Given this list of marker genes SLIT2, ID2, RYK, OPRM1 (opioid receptor mu 1, NCBI Gene Id 4988), RARB, NEURL1, DRD2, MIR222, SHANK3, NRXN1, FXR1, WASF3, TNFRSF1B, MYB, HOXB3, CTNNB1, HES6, LRTM2, TIAM2, SEMA3F, BDNF (brain derived neurotrophic factor), PTPRS, ELL3, POU4F2, NCMAP, OLIG2, FBXW8, DRAXIN, FGF13, NFATC4, PRUNE1, DAG1, S100B, NPTN, PCM1, GATA2, EGR2, RELN (reelin), CX3CR1, SOX11, KIT, LEF1, DHX36, SLIT1, TNFRSF21, LRRTM3, SRF, DKK1, B2M, IL34, FZD4, FEZF1, AGRN, PER2, QKI, KIFAP3, GPR37L1, REST, CTDSP1, LRRTM1 (leucine rich repeat transmembrane neuronal 1), SKI, RUFY3 (RUN and FYVE domain containing 3), AKT1, PARD3, FN1, MECP2, S100A10, NLGN2, DCT, FXR2, LRRTM2 (NCBI Gene Id 26045), L1CAM, SMURF1, KDM1A, LYN, HMGB2, TG, MAP6, TPPP, TP53, CHODL, ARHGAP4, TTBK1 (tau tubulin kinase 1), IL6ST, IST1, GHRL, GBX1 (gastrulation brain homeobox 1), CBLN2, EZH2, CDK18, MIR137, PARP6, AMIGO1, SEMA4A, PLXNB2, SEMA6C, PROX1 (NCBI Gene Id 5629), VAX1, ITPKA, VEGFA, EPHB1 (NCBI Gene Id 2047), NLGN3, SLC7A5, SERPINF1, ZNF335, RARG, IQSEC2, CUX1, DAAM2, NLGN1, FEZF2, SLITRK2, AMIGO3, NR1D1, GSX2, ST8SIA2, ANAPC2, BCL11A, HES5 (hes family bHLH transcription factor 5), APPL2, RNF112, EPHA7, CXCL12, CTNNA1, VSTM5, HES3, ADGRB2, E2F1, TYMP, RND2, BMAL1, DLL1, CLCN2, PRTG, IGF1, GRM5, METRN, NUMB, FGF2 (fibroblast growth factor 2), ANKRD27, MEGF8, DICER1 (NCBI Gene Id 4333), MIR221, LIF, SOX10, ADGRB3, ASIC2, SS18L1, CRABP2, DNAJB11, PTN, ATXN1, HMGA2, ADGRB1, SLITRK6 (NCBI Gene Id 84189), WNT7A (Wnt family member 7A), CHD7, MIR181C, CAPRIN2, NTRK2, DLG5, GPRASP3, FMR1, RNF6, NRP1, BAIAP2, MIR142, ROBO2, TENM4, PLXND1, NOS1, RB1, CLCF1, TRAK2, NOTCH1 (NCBI Gene Id 54781), PRMT5, PRKCA, EFNA5, SRPX2, NRDC, SRRT, OXT, IL6, DMRTA2, PLXNC1, ANXA2, KIAA0319, SORL1, VEGFC, EPHB2, SYNGAP1, DSCAM, GPER1, NKX6-1, DCC, FSTL4, LIMK1, HOOK3, CST7, ULK1 (NCBI Gene Id 8408), ASPM, PRKCH, YAP1, LRRN1, CX3CL1, SEMA4F, FLRT2, YWHAH, EEF2K, LRRC4B, HEYL, MIR181B1, SEMA3G, GOLGA4, PAFAH1B1, TIAM1, ITGB1, SLC30A1, NEFL, SEMA6D, DAB1, MAP3K13, LHX2, SOX8, GORASP1, ITGAX, MT3, RHEB, TWF2, RNF10, WNT2, DLX2, DLL4, EFNB3, LRP2, DOCK7 (dedicator of cytokinesis 7), BMP2, NOG, FIG4, ISLR2, NIN, DRD3, HDAC1, MYRF, HDAC2, CAPRIN1, SMARCD3, RTN4, KRAS, LPAR3, CDON, DISC1, SPP1, MIR125B1, STK11, MAP2K1, OBSL1, AMIGO2, RARA, UFL1, TPBG, DLX1, ROBO1, NTN1, DLL3, ZNF365, FLRT1, EIF2AK3, DIP2B, MAP1B, CAMK2B, NR2E1, TRIM32, FZD3, GBX2, STAU2, SIRT2, GRID2, THBS2, MAN2A1, MTOR, ZFYVE27, TGM2, PAX6, ZNF488, ADCY10, LIN28A, TMEM98, LINGO2, F2, SEMA5A, IDH2, MAPT, RASSF10, TSPO, LRRN3, PLAG1, DPYSL5, LRP4, SPEN, SPINT1, PAK1, CLSTN1, SLITRK1, LDLR, LTA, PLXNA3, ADNP, ID4, PTEN, PSEN1, RTN4R, PTPRD, KHDC3L (NCBI Gene Id 154288), NKX6-2, PRKCI, PPP1CC, SLITRK5, MACF1, BTG2, BHLHE41, IL1B, SEMA7A, CDKL3, IL1RAP (NCBI Gene Id 3556), HAP1, YTHDF2, CDK5, HEY1, KCTD11, MTMR2, ETV5, LRRC24, VSX2, HEY2, TP73, TLX2, MCF2, BRAF, SERPINE2, IFRD1, DUSP10, EPHA4, TLR2, CDH4 (NCBI Gene Id 79941), FERD3L, PTPN13, BMPR2, ELAPOR2, CXCR4, NGF, CUL7, TREM2, IL1RAPL1, PTPRZ1, ZEB2, SEMA4D, TNFRSF12A, LPIN1, TNF, CLSTN3, SLITRK4, NTRK3, HIF1A, WNT3, DYNLT1, WNT3A, SNW1, ASCL1, KIF14, BRINP1, XRCC5, ULK2, SMO, CDH1, PLXNB1, SHH, POU4F1, WDR62, NUMBL, HES2, HELT, GLI3, WNT5A, TRPC5, MAP2K2, NKX2-2, LRP8, RELA, JAM2, FLRT3, PITX3, MDK, CUX2, HES7, ATOH1, ZPR1, DBN1, TRAK1, TGFB1, SYNDIG1, NAP1L1, TRIM46, BMPR1A, HLTF, RGMA, GDI1, SHTN1, ASCL2, ARMCX5-GPRASP2, BMP7, MME, HDAC6, STK25, TRPV2, RAPGEF2, PPP3CA, NF2, NF1, TNR, TRIM11, SLITRK3, SPART, CTSC, SHOX2, FOXG1, MAG, MIR146A, MYCN, SKIL, CERS2, BHLHE40, LINGO4, LIG4, TRPC6, OTP, ABCC8, MAP2, CBLN1, NTRK1, NSUN5, TBC1D24, EPHB3, XRCC2, IFNG, LGI4 (leucine rich repeat LGI family member 4), HES1, RAB21, SYT4, CCL11, THY1, GFAP, PLXNB3, DLG1, BIN1, RGS14, CDKL5, CLSTN2, here is a description of the gene set: studied in species Homo sapiens Any process that modulates the frequency, rate or extent of nervous system development, the origin and formation of nervous tissue. Human Gene Set: GOBP_REGULATION_OF_NERVOUS_SYSTEM_DEVELOPMENT